The following is a description of a gene set: Mouse Gene Set: GOBP_NEUROTRANSMITTER_REUPTAKE The directed movement of neurotransmitter molecules from the extrasynaptic space into the presynaptic cytosol. species: Mus musculus, and this is the list of marker genes: Nos1, Slc22a3, Slc6a2, Tor1a, Slc18a2, Drd2, Slc18a3, Kcnj10, Itgb1, Snca, Slc18a1, Rab3b, Slc6a4, Itgb3, Per2, Slc6a1, Slc29a4, Gdnf, Park7, Prkn, Fev, Cln8 (NCBI Gene Id 26889), Nat8l, Slc18b1, Slc1a2, Slc22a1 (solute carrier family 22 (organic cation transporter), member 1), Slc17a8, Gpm6b, Slc22a2, Slc6a5